Given this list of marker genes DIPK1A (divergent protein kinase domain 1A), ENPP5, CLCN3, ADAM8, TEX44, ENPP6, CCNE2 (NCBI Gene Id 9134), USP35, INTS5, FAM13A, ADAM20, NUDT19, FASTKD3, MBOAT7, UFD1, ZMAT4, PLLP, FSCN1, XBP1, CD84, SNTB1, RRS1, NRP2, CD55, ADGRA3, SUCO, SLC6A1, EIF1B-AS1, MAPK6, IL13, ZYG11B, RXFP1, DACH1, STARD4, EPAS1, CPT1A, CNKSR2, AUTS2, EPDR1, TDH, CLDN5, MPZL2 (myelin protein zero like 2), TPD52, C9orf78, VCL, EEIG2, RAB27B, TTC33, C1orf53, VSIG10L, PPP1R14A, CTNNAL1, ELAPOR2, HEG1, SKA2 (spindle and kinetochore associated complex subunit 2), C12orf76, HPS3, KPNA6, ZMYM5, SAMD3, TXNRD1, ZNF84, GFI1, LRWD1, MSI2, SLC50A1, SSBP2, WWC3, LINC01619, LEO1, GPALPP1, PHF20L1, ERLEC1, PTPRE, RNF19A, KIAA0513, PLCL1, KCTD9, CD244, GATA3, HPCAL1, RAB30, DUSP6, ATP6V0A2, SOX4, SDC4, ABCD3, C16orf87, RNF146, ANTXR2, AMPH, POC5, CCDC71L, GAB2, CENPU, SLC22A5, RASGRP3, ZNF677, DMXL2 (Dmx like 2), RCAN1, RBM14, TSPAN13, MTX3, TPRG1, TXLNB, CAND2, SP4, GPR183, OSBPL1A, SPAG1, ZMYM4, DIPK2A, LEMD2, ZFYVE9, TPH2, PLXDC1, PXT1, LINC01281, FYN, FAM241A, GNAI1, CDC45, CLECL1P, SMAD2, PPP4R2, CUX2, CAMSAP1, TET3, SMC4, OR7E19P, VMP1, FAM13A-AS1, LINC01127, SLC39A8, NSUN3, NET1, MAOA, EIF1AD, WDR44, KCNK5, NCOA3, OR5V1, TAF3, SVIL, BLTP3B, GAB3, ERMP1, LARS2, BUD13, HIPK1, CD40LG, ASAP1, CCDC85C, ZIC3, PPARG, UBL3, CHSY1, F11R, UPRT, CHN2 (NCBI Gene Id 644086), MOSPD3, NIPA1, PTPRK, ZNF443, MFSD6, RNF125, SATB1, NFU1, EVI2B, LIMA1 (LIM domain and actin binding 1), NABP1, SOCS1, PTPN14, MIER3, DLC1 (NCBI Gene Id 94517), POU3F2, TPM1, NOMO3, GPCPD1, VSTM4, FOXL1, IL10RA, STAT4, SPINT2, CTNS, CAMK2D, TFDP1, TRIB1, CDCP1, GFPT1, LINC00205, DNAJB9, TEX30, CTH, here is a description of the gene set: The aim of this dataset was to study in detail the transcription kinetics initiated by cytokine IL-4 in early differentiation of Th2 cells. Human Gene Set: GSE17974_IL4_AND_ANTI_IL12_VS_UNTREATED_12H_ACT_CD4_TCELL_UP Genes up-regulated in comparison of CD4 T cells treated with IL4 and anti-IL12 at 12 h versus the untreated cells at 12 h. studied in species Homo sapiens from publication Elo LL, Järvenpää H, Tuomela S, Raghav S, Ahlfors H, Laurila K, Gupta B, Lund RJ, Tahvanainen J, Hawkins RD, Oresic M, Lähdesmäki H, Rasool O, Rao KV, Aittokallio T, Lahesmaa R (PMID 20620947)